Given this list of marker genes EPB41, B3GALT5, RABGAP1L, FAM114A1, KANSL1L, RSAD1, FAXC, RAB1A, SPEF2, HNRNPUL1, HOXA11, CDH11, KLRD1, PPM1A, DSG3, LIPH, NAA25, IKZF5, SYT1, PBX1, APLF, PRP4K, ACADSB, ARHGAP12, LRRFIP1, GBP7, SULF2, ZNF608, PIAS2, PLCL2, SUZ12, ETV5, SLC22A3, MLF2, ZNF543, CDH13, LAS1L, CNTF (ciliary neurotrophic factor), CLCNKA, HNRNPC, CSGALNACT2, ZSWIM6, IRAK1BP1, ALS2, POLH, RAB6B, CCR2, LRRN1, ELAVL2, FGF13, FASLG, DCTN2, NDRG1, CEP85L, PDZRN3, L1CAM (NCBI Gene Id 4268), NELL2, MDGA2, SLITRK6, DPP8, STRN, BZW1, CPSF7, PCGF3, BTBD3, FOXP2, LRRC75A, UBE2K, SYNCRIP, MBNL1, here is a description of the gene set: species: Homo sapiens Genes predicted to be targets of miRBase v22 microRNA hsa-miR-6514-3p in miRDB v6.0 with MirTarget v4 prediction scores > 80 (high confidence targets). from publication Chen Y, Wang X (PMID 31504780) Human Gene Set: MIR6514_3P